Given this list of marker genes ZNF761, CRACDL, GPR158, ZNF728, ZNF888 (zinc finger protein 888), ZC3HAV1L, GPX8, ZNF721, MGP, STXBP5, DCUN1D4, SRC, OXR1, SRSF11, PDCD10, USP49, SNAP91, NRF1, BPTF, ZNF614, NRTN, PIN4, MAPK6, ZNF749, NPAP1, ZNF93, ZNF124, ZNF578, SLITRK6, HEATR5A, ZNF737, EPHA4, SYNPO2, GALNT16, FBXL3, TPT1, CFL2, ZNF268, OGA, ZNF138, RNF150, ZNF439, ZNF816-ZNF321P, SRSF1 (NCBI Gene Id 650453), ZNF83, PCDHB13, ZNF468, CREBRF, ZNF714, RPS6KB1, ARF1, ZNF107, ZNF816, TRIM33, PLCB1, CHST11, GCH1, TTC38, ZNF732, ZNF676, HAS2, MCU, ZNF208 (NCBI Gene Id 7757), ZNF493, MSN, CASD1, ZNF681, ZNF813, ZNF117, UGT2B7, SLC39A14, RFWD3, SLC35F1, ZNF91, ZNF267, ZNF611 (zinc finger protein 611, NCBI Gene Id 81856), UMOD, ANO6, SEMA6D, ZNF99, TRIB2, ADA, CBLB, ZNF655 (NCBI Gene Id 79027), ZNF845, PTPRF, ZNF716, GOLGA6L6, FAXC, MOB4, NAA15, RO60, MAP4K3, SEMA5A, GNB1 (G protein subunit beta 1), VIL1 (villin 1), CAPN7, THBS4, ZBTB18, ZNF626, ZNF708, FZD3, ELMOD1 (ELMO domain containing 1), FOXN3, CPA6, SEL1L, PTEN, ZBTB44, RAB3C, EGR1, ZNF730, UGT2B28, ZNF701, PRKAG1, CRYL1, ATE1, ARK2N, ZNF28, ZNF844, ZNF559 (NCBI Gene Id 84527), ARID4B, MAT2B, TPP2, FOXN2, AKAP5, ZNF440, DDX3X, PITHD1, NAPB, DISC1, ZNF600, ZNF195, REEP3, ZNF765, PTBP2, CORIN (corin, serine peptidase), ZNF682, LUZP1, OSBPL6, GOLGA6L1, MAPK8, GABRG1, RGS7BP, FCHSD2, RANBP9, BCL2L11, BHMT2, ZNF92, DNAJC6, BBX, ANKRD50, DPYD, ZNF808, ITPR2, ZNF610, GAP43, PJA2, LZTS1, DYNC2LI1 (dynein cytoplasmic 2 light intermediate chain 1), GRM3, DPY19L3, ZNF415, ZNF700, TAB3, NAB1, MAGEB1, here is a description of the gene set: Genes predicted to be targets of miRBase v22 microRNA hsa-miR-3064-3p in miRDB v6.0 with MirTarget v4 prediction scores > 80 (high confidence targets). from publication Chen Y, Wang X (PMID 31504780) studied in species Homo sapiens Human Gene Set: MIR3064_3P